The following is a description of a gene set: The process in which SRP binds to the signal peptide in a nascent protein, causing protein elongation to pause, during cotranslational membrane targeting. Human Gene Set: GOBP_SRP_DEPENDENT_COTRANSLATIONAL_PROTEIN_TARGETING_TO_MEMBRANE_SIGNAL_SEQUENCE_RECOGNITION studied in species Homo sapiens, and this is the list of marker genes: SNAP25-AS1, SRPRB, TTC9-DT, BHLHE40-AS1, RN7SL1, GJD2-DT, SRP54, ENSG00000283175, SRP19, RN7SL3, RN7SL2, SRPRA